Given this list of marker genes GATA3, SPN, FUT7, ZP3, IL20RB, here is a description of the gene set: Human Gene Set: GOBP_TYPE_IV_HYPERSENSITIVITY An inflammatory response driven by T cell recognition of processed soluble or cell-associated antigens leading to cytokine release and leukocyte activation. species: Homo sapiens